Given this list of marker genes IQSEC2, KIF5B, AASDHPPT, TRPM1, ARMC3, XPO1, NECTIN1, AFTPH, PTPN23, PCMT1, MYL12A, RALGDS, ATP2B4, RNF148, NUDT19, CADPS, CARNS1, THRB, AKIRIN2, TM9SF1, ITGA3, TMED3, MDK, MDGA1, ALOX15, NBN, RANBP6, ARHGAP36 (NCBI Gene Id 158763), DTD1, CUL4B, MUC13, CHID1, BTBD1, ATXN7L3B, ARF3, COL4A3, MEIS2, USP31, CAMK4, KLHDC1, RIPOR2, ADAM22, PABIR1, TNN, SNX18 (sorting nexin 18), MAPK8, KCNA6, STAG1, PPT1, DENND3, here is a description of the gene set: Human Gene Set: MIR6862_5P Genes predicted to be targets of miRBase v22 microRNA hsa-miR-6862-5p in miRDB v6.0 with MirTarget v4 prediction scores > 80 (high confidence targets). from publication Chen Y, Wang X (PMID 31504780) studied in species Homo sapiens